Given this list of marker genes Dusp10, Prkg1, Nfatc1, Tab1, Mapk14, Dusp16, Prmt1, here is a description of the gene set: Mouse Gene Set: GOMF_MITOGEN_ACTIVATED_PROTEIN_KINASE_P38_BINDING species: Mus musculus Binding to mitogen-activated protein kinase p38, an enzyme that catalyzes the transfer of phosphate from ATP to hydroxyl side chains on proteins in response to mitogen activation.